The following is a description of a gene set: A developmental defect resulting in the congenital absence of skin on the trunk or the limbs. studied in species Homo sapiens Human Gene Set: HP_APLASIA_CUTIS_CONGENITA_ON_TRUNK_OR_LIMBS Aplasia cutis congenita on trunk or limbs, and this is the list of marker genes: ARHGAP31, ITGB4, KRT5, PLEC, KRT14, ITGA6